Given this list of marker genes NUP35, NUP160, NUP205, AAAS, POLR2D, NUP58, NUP107, NUP50 (nucleoporin 50), RAE1, POLR2K, NUP214, RANBP2, POLR2F, NUP37, NUP153, POLR2H, NUP42, SEC13, NUP62, POLR2G, NUP210, TPR, POLR2C, SEH1L, NUP93, POLR2A, NUP43, POLR2I, NUP98, POLR2J, NUP85, NUP188, POLR2E, NUP54, NUP155, NUP88, POLR2L, GTF2F1, NDC1, NUP133, POM121C, POLR2B, GTF2F2, POM121, here is a description of the gene set: Human Gene Set: REACTOME_VIRAL_MESSENGER_RNA_SYNTHESIS Viral Messenger RNA Synthesis studied in species Homo sapiens